The following is a description of a gene set: Genes predicted to be targets of miRBase v22 microRNA mmu_miR_6370 in miRDB v6.0 with MirTarget v4 prediction scores > 80 (high confidence targets). from publication Chen Y, Wang X (PMID 31504780) Mouse Gene Set: MIR_6370 species: Mus musculus, and this is the list of marker genes: Nt5c3, Prkaa1, Pramel16, Pip4p2, Sult2a1, Actr2, Thumpd1, Ctbs, Agpat5, Katnb1, Rora, Sycp3, Azi2, Hecw2, Adcy3, Tnfrsf10b, Cdh1, Pcsk5, Btbd9, Cd151, Erlin2, Trappc14, Serpina3f, Slc25a3, Yipf4, Pard3, Pfkfb2, Upf3b, Capza2, Map4k3, Sertad4, Ankrd27, Map3k7, Foxk2, Ide, Gja8, B3galt5, Jcad, Scd1, Prr16, Tmem266, Cemip2, Bin1, Phf6, Zfp953, Aqp4, Cc2d1b, Kctd8, Zswim5, Krtap10-31, Foxa1, Gprasp1, Kcnc2, Gm5878, Wdr6, Rnf20, Atp8b2, Ssbp2, Hnrnpk, Pramel12, Tet2, Kpna1 (NCBI Gene Id 16646), Atg14, Cacnb4, Adamts15, Zfp609, Smim10l1, Tnik (TRAF2 and NCK interacting kinase), Abca1, Cd34, Epc1, Sgsm2, Hpse2, Swt1, Srrm2, B3gnt6, Crxos, Abcc5, Arid1a, Lrit2, Cyld, Ccin, Celf2, Hars2, Dapk2, Timm22, Hdgfl3, Nptn, Tspan13, Zeb1, Gpatch2l, Sult2a4, Tnp2, Flot1, Slc25a14, B230219D22Rik, Padi2, Hnrnpd, Pou3f2, Rnf152, Mlxipl (NCBI Gene Id 58805), Sult2a5, Hnrnpm, Bcl7a, Ostm1, Zc3h12c, Zc4h2, Krtap17-1, Acnat1, Sult2a2, Map3k12, Tnrc6b, Pgk1, Zbtb7c, Fhip1a, Tmem87a, Fbn2, Strbp, Neto1 (NCBI Gene Id 246317)